Given this list of marker genes Actn2, Pdxp, Carmil2, Cfl2, Cfl1, Dstn, Carmil1, Cracd, Vil1, F2rl1, Wdr1, Plek, Sema5a, here is a description of the gene set: Any process that activates or increases the frequency, rate or extent of actin depolymerization. Mouse Gene Set: GOBP_POSITIVE_REGULATION_OF_ACTIN_FILAMENT_DEPOLYMERIZATION species: Mus musculus